The following is a description of a gene set: studied in species Homo sapiens Any process that modulates the frequency, rate or extent of opsonization. Human Gene Set: GOBP_REGULATION_OF_OPSONIZATION, and this is the list of marker genes: COLEC11, PLA2G5, FCN3, COLEC10, FCN1, C4BPB, MBL2, MYO18A, CFP, C4BPA (complement component 4 binding protein alpha), FCN2